Given this list of marker genes PRRX1, KIAA1549L, KRT73, PABIR2, GABARAPL2, AKT2, XRCC5, MGAT4A, RAP2A, HECA, MDH1B, TRAM2, MSL1, TMEM104, SKP1, RPE, ITSN1, SHISA7, PLCD3, WDFY2, NOS1, GLRX, KCTD21, NTNG1, ARNT, TRAFD1, RPL23A, MS4A6E, ZNRF1, KPNA3, NUFIP2, TRIM44, RNF169, TRPS1 (NCBI Gene Id 7227), KRT72, SAMD12, NRP1, CHST2, BAG1, MNT, REDIC1, PFKFB2, CRNN, FNDC3B, KPNA1, LSM6, NIPA2, DYRK1A, PINLYP, CCDC186, PTK2, MAPK4, GPR176, RASD2, MADD, TAF2, TMEM266, IYD (NCBI Gene Id 389434), FHIP2A, TECPR2, EMID1, CTXN2, ASCC1, TROAP, TSPAN5, NT5DC3, MKRN1, CRYBG1, USP54, ICA1, SLC9A8, GTDC1, AQP2, HNRNPU, EXOC2 (exocyst complex component 2), HBP1, ACTL6B, NOVA1, METAP1, CREB1 (cAMP responsive element binding protein 1), DSC3, RGMB, CPA6, UCHL1, PDE4DIP, FAM78A, LAMC2, GPX5, SLC35G1, MSI2, KCNB1, PRICKLE2, DMRT2, CMTM4, TUBB2A, SLC1A2, TMPRSS11B, G3BP2, GALNT2, KRIT1, RHOQ, SMAD2, NFIB, OGFOD1, SAPCD1, EPN2, DDB1, PPP1R9B, ANKMY2, OR12D3 (olfactory receptor family 12 subfamily D member 3), ZNF99, ATP8A1, SYT17 (synaptotagmin 17), HAPLN4, EFCAB11, UNC13D, ATF6, GRIK4, TAOK1, ZNF664, COPB1 (COPI coat complex subunit beta 1), TMEM221, here is a description of the gene set: studied in species Homo sapiens from publication Chen Y, Wang X (PMID 31504780) Human Gene Set: MIR5004_5P Genes predicted to be targets of miRBase v22 microRNA hsa-miR-5004-5p in miRDB v6.0 with MirTarget v4 prediction scores > 80 (high confidence targets).